The following is a description of a gene set: species: Homo sapiens Any process involved in the carrying out of an immune response by a T cell. Human Gene Set: GOBP_T_CELL_MEDIATED_IMMUNITY, and this is the list of marker genes: RAET1E, IL4I1, MR1, HPRT1, IL18 (interleukin 18, NCBI Gene Id 3606), AHR, ARID5A, FBXO38, CD46, ZBTB1, PRF1, XCL1, MAPK3, SMAD7, CCR2, TRAF2, C4BPA (complement component 4 binding protein alpha), CADM1, IFNB1, CTSC, IL4, GNL1, KLRD1, AGER, TNFSF4, FCGR2B, KLRC1, GZMM, JAG1, HSPD1, PPP3CB (NCBI Gene Id 5532), HLA-DRB3, CEACAM1, CR2, SLC22A13, RFTN1, HLA-DRA, HMGB1, CLC, ULBP2, MAP3K7, IL1R1 (NCBI Gene Id 3554), ULBP3, IL7R, EBAG9, HLA-A, YWHAG, CRTAM, CD274, SLAMF1, CD80, USP5, IFNA2 (interferon alpha 2), IL12B, SPN, ULBP1, ICAM1, UFL1, ZP3, CD1A, IL6, CD81, PTPRC, CR1, STX7, WAS, RAET1L, DUSP22, IL20RB, TRAF6, FUT7, HLA-B, HLA-G, RAET1G, HLA-F, TAP2, CD70, PDCD1, IL1B, IL12A, IL12RB1 (NCBI Gene Id 3594), MALT1, TBX21, IL23A, MICA, BTN3A3, CD8A, CR1L, KDM5D, MYO1G, NFKBIZ, LILRB4 (leukocyte immunoglobulin like receptor B4), GFUS, CD55, PRKCZ, PVR, CD7, RIPK3, CTSH, EMP2, SCART1, CD1E, TNFRSF1B, RAB27A, DENND1B, CLEC4G, RSAD2, HLA-E, CD1C, PRKAA1, FADD, UNC93B1, GATA3, AZGP1, NLRP3, P2RX7, FZD5, LILRB1, BTN3A2 (butyrophilin subfamily 3 member A2), B2M, NCKAP1L, CD1D, HLA-H, TREX1, KLHL22, NECTIN2, FOXP3 (forkhead box P3), ARG1, TRPM4, CD1B, CYRIB, SASH3, IL18R1, HLA-DRB1, AIRE, IL23R, SECTM1 (NCBI Gene Id 6398), HFE, HLA-C